Given this list of marker genes FERMT1, COL7A1, TERC, TBX1 (NCBI Gene Id 7413), METTL27, NHP2, DNAJC30, MKKS, BAZ1B, TBL2, RTEL1, USB1, SPRED1, TYMS, EIF4H, ITGB4, CDC45, LAMA3, TMEM270, CLIP2, TERT, CTC1, PLEC, LIMK1, WRAP53, MMP1, NOP10, LAMB3 (NCBI Gene Id 3914), BUD23, ZMYM2, RFC2, FLNA, FKBP6, NPM1, PTPRF, LAMC2 (laminin subunit gamma 2), SIN3A, BNC2, GTF2IRD1, PARN, MED25, NCF1 (neutrophil cytosolic factor 1), GTF2I, DKC1, POLA1, FLT4, TP63, MAP3K7, RIN2, ELN, GTF2IRD2, MLXIPL (MLX interacting protein like), TINF2, STX1A, ITGA6, VPS37D, PKP1, here is a description of the gene set: Human Gene Set: HP_URETHRAL_STENOSIS Urethral stenosis Abnormal narrowing of the urethra. studied in species Homo sapiens